The following is a description of a gene set: Human Gene Set: GSE8868_SPLEEN_VS_INTESTINE_CD11B_POS_CD11C_NEG_DC_DN from publication Denning TL, Wang YC, Patel SR, Williams IR, Pulendran B (PMID 17873879) The intestinal immune system must elicit robust immunity against harmful pathogens but restrain immune responses directed against commensal microbes and dietary antigens. The mechanisms that maintain this dichotomy are poorly understood. Here we describe a population of CD11b+F4/80+CD11c– macrophages in the lamina propria (LP) that express several anti-inflammatory molecules including interleukin 10 (IL-10), but little or no pro-inflammatory cytokines, even upon stimulation with Toll-like receptor (TLR) ligands. These macrophages induced, in a manner dependent on IL-10, retinoic acid and exogenous transforming growth factor-β, differentiation of FoxP3+ regulatory T cells. In contrast, LP CD11b+ dendritic cells elicited IL-17 production. This IL-17 production was suppressed by LP macrophages, indicating that a dynamic interplay between these subsets may influence the balance between immune activation and tolerance. Splenic or small intestine lamina propria CD11b+11c- cells were isolated for RNA extraction and hybridization on Affymetrix microarrays. We sought to determine the unique genetic profile of small intestine lamina propria CD11b+11c- cells. studied in species Homo sapiens Genes down-regulated in dendritic cells (DC) from spleen versus those from intestine., and this is the list of marker genes: NUDT11, APOA2, MORN2, TMCC3, MOAP1, CLTB, IRAG1, RAMP3, PFN2, NUDT14, SLC37A2, BEND3, ARHGAP6, ZNF263, RNFT1, HNRNPAB, CASP8, PDHB, SPECC1L, CMTM3, PRDM8, PTRH1, BASP1, ICAM1, KLHL7, NCOA7, WEE1, TGIF1, ALG9, RSAD1, HLA-G, MLLT6, SNX3, AIF1, TCEAL8, CPE, LAMP1, HERPUD1, PDLIM4 (PDZ and LIM domain 4), SCAMP5, GBF1 (NCBI Gene Id 8729), ZMYND15, TPM2, MLH1, COL1A1 (NCBI Gene Id 4970), LYVE1, MANSC1, CNBP, MRTFB, NAF1, SGCB, GALC, FAM3C, CYP51A1, EFCAB14, MNT, FLNB, BBS5, CD80, TMEM107, EPOR, ENY2, SDC1, MYO3A, CLASP2, NEURL1, P2RY12, PHLDB1, CD69, ITGA5, CTTNBP2NL, MB21D2, PARVA, CIAO2B (cytosolic iron-sulfur assembly component 2B), IFNAR1, BARD1, PLS3, SNRPA, ACP5, ADAM19, BUB1, REL, GNS, SLC25A28, CD164, SLC39A8, PORCN, IPO4, HIC2, DNAJC1, FYB1, GNB1L, RHBDF1, IK, LIMA1, ARSK, EGLN2, LYPLAL1, SLC10A6, AGMO, DNAL1, ARIH2, FADS2, DNAJB6, IST1, AP1B1, NCS1, ACP2, GDI2, LIX1L, TSPAN33, CNKSR3, POPDC3, TCF12, PLIN2, LAIR1, APOLD1, RBP1, SLC31A2, VMA21, SMCO4, GPAM, IGSF10, HLA-B, POGLUT2, ENTREP1, COPRS (NCBI Gene Id 95076), CALML4, MTHFR, NPY, CLEC1B, EIF4E, CD72, DPYSL3, IGKC, TENT5C, CHL1, OTC, AMPH, MT2A, TLE6, EPRS1, PTPMT1, CYSLTR1, BLVRB, SCGN, VAV2, CLDN7, MYOM1, DIP2C, FIBIN, DLG5, PDK3, IL4R, CCL13, ATF4, NDC1, AK1, TRIM13, CSF2, MRAS, STMN3, FAM135A, KRT8, HIRIP3, SAMD11, DSE, PLA2G2D, CA13, DNM1L, CALR, MT1E, LRAT, SERPINB8, MTHFD1, LRP12, ZRANB3, FADS1, SLC16A6, SMARCAL1, BAIAP2, HOXC4, SEMA4C, NFATC2, MAPK8, GALNT2, KCNIP3, ARL4C, FCGR1A, MEIOB, PABIR2, HSP90AB1, QPCT, MYH10, EYA3, BNIP5, UBE2N, SECTM1, SLC35F5, HSPA5